Given this list of marker genes CDKN1C, NTRK3, SPRY2 (sprouty RTK signaling antagonist 2), FZR1 (fizzy and cell division cycle 20 related 1), PLAAT1, HSF4, PROX1, WNT7A, NF2, TBC1D20, SKIL, WNT7B, PITX3, CRYAA, ABI2, FGF2, FOXE3, BFSP2, SMAD3, ATF4, EPHA2, KDM5B, CRYGD, CDKN1B, PLAAT3, SPRED3, CRYGB, TDRD7 (NCBI Gene Id 23424), TMOD1, ZEB2, SPRED2, VIM, MAF, SPRED1, SPRY1, BFSP1, SIX3, WNT5B, TGFB1 (transforming growth factor beta 1), FRS2, here is a description of the gene set: studied in species Homo sapiens The process in which a relatively unspecialized cell acquires specialized features of a lens fiber cell, any of the elongated, tightly packed cells that make up the bulk of the mature lens in the camera-type eye. The cytoplasm of a lens fiber cell is devoid of most intracellular organelles including the cell nucleus, and contains primarily crystallins, a group of water-soluble proteins expressed in vary large quantities. Human Gene Set: GOBP_LENS_FIBER_CELL_DIFFERENTIATION